Given this list of marker genes LZTR1, PIEZO2, FBN2, MYBPC1, PI4KA, SRPX2, ACADM, CCDC47, REEP1, MYOD1, YY1, GLI3, CHST14, NRCAM, MYO9A, DHCR24, TNNI2, MED13L, MYH8, LGI4, ADGRG1, GLDN, ATAD1, FIG4, ADCY6, CNTNAP1, COQ4, here is a description of the gene set: Human Gene Set: HP_DISTAL_ARTHROGRYPOSIS Distal arthrogryposis An inherited primary limb malformation disorder characterized by congenital contractures of two or more different body areas and without primary neurologic and/or muscle disease that affects limb function. species: Homo sapiens